Given this list of marker genes Micu3, Slc25a1, Pam16, Smdt1, Slc25a51, Slc25a37, Vdac2, Romo1, Timm23 (NCBI Gene Id 53915), Ccdc51, Tomm40l, Slc25a29, Slc30a2, Ghitm, Timm44, Sfxn1, Slc25a38, Tomm7, Mrs2, Tomm20l, Mpc1, Sfxn3, Mcub, Slc25a40, Hspd1, Spg7, Slc41a3, Letm1, Psen2, Mpc2, Tst, Micu2, Ucp1, Slc25a2 (NCBI Gene Id 83885), Hspa9, Abcb8, Slc25a4, Maip1, Dnlz, Pnpt1, Fxn, Timm21, Slc25a28, Slc25a15, Adcy10, Letm2, Aifm1, Slc25a21, Cpt2, Slc8b1, Sfxn2, Mcu, Gfer, Hif1a, Grpel1, Grpel2, Itpr1, Slc25a26, Sfxn4, Slc25a5, Dnajc15, Abcb7, Mcur1, Slc25a3, Chchd4, Akt1, Slc39a8, AU015836, Slc25a32, Tomm70a, Sfxn5, Slc25a24, Opa1, Afg3l2, Slc25a20, Mrpl18, Tomm40, Ucp2, Timm50, Col6a1, Slc25a36, Tomm20, Bhlha15, Slc25a41, Slc25a23, Timm17b, Slc8a3, Cpt1b, Slc25a39, Slc25a16, Slc25a33, Dnajc19, Timm17a, Slc25a31, Abcb10, Micu1, Selenon, Vdac1, Ucp3, here is a description of the gene set: The process in which a solute is transported from one side of a membrane to the other into, out of or within a mitochondrion. species: Mus musculus Mouse Gene Set: GOBP_MITOCHONDRIAL_TRANSMEMBRANE_TRANSPORT